Given this list of marker genes TIPIN, TIMELESS (NCBI Gene Id 8914), SLFN11, DYNLL1, BCL6, LIG3, GMNN, FBXO5, CAMSAP3, CDT1, here is a description of the gene set: studied in species Homo sapiens Any process that stops, prevents, or reduces the frequency, rate or extent of DNA-dependent DNA replication. Human Gene Set: GOBP_NEGATIVE_REGULATION_OF_DNA_TEMPLATED_DNA_REPLICATION